The following is a description of a gene set: Any process that activates or increases the frequency, rate or extent of the chemical reactions and pathways resulting in the breakdown of nucleotides. studied in species Mus musculus Mouse Gene Set: GOBP_POSITIVE_REGULATION_OF_NUCLEOTIDE_CATABOLIC_PROCESS, and this is the list of marker genes: Igf1, Slc4a4, Sik2, Ifng, Prxl2c, Ins2, Zbtb20, Prkaa2, Ins1, Rptor, Kat2b, Myc, Mlx, Src, Hif1a, App, P2rx7, Gpd1, Gapdhs, Mtor, Arnt, Uchl1, Insr, Mlxipl, Gck, Htr2a, Psen1, Esrrb, Ppp2ca, Mlst8, Pfkfb1, Gpi1, Prkaa1